Given this list of marker genes CHRNA5, CHRNA4, CHRNA1, CHRNA2 (NCBI Gene Id 1135), CHRNB2, CHRNA3, CHRNB4, CHRNB3, CHRNA6, here is a description of the gene set: Nicotinic acetylcholine receptors exhibit high influx of Ca2+, the degree of Ca2+ permeability is dependent on the subunit composition; homomeric acetylcholine receptors containing aplha 7 subunits allow maximum Ca2+ influx followed by receptors containing alpha3 beta2 alpha5 or alpha3 beta4 alpha5. part of: Presynaptic nicotinic acetylcholine receptors Reactome Pathway: Highly calcium permeable nicotinic acetylcholine receptors studied in species Homo sapiens